Given this list of marker genes Plpp3, Synj1, Ephx2, Plppr2, Chrm5, Mtmr12, Mtmr1, Plpp5, Pip4p1, Plpp4, Fig4, Mtm1, Mtmr9, Inppl1, Sgpp1, Mtmr2, Plppr3, Synj2, Mtmr11, Inpp5d, Inpp5k, Mtmr6, Plpp6, Mtmr3, Pten, Inpp5b, Plppr4, Inpp4b, Plppr5 (NCBI Gene Id 75769), Inpp5a, Plpp2, Inpp5j, Plpp1, Inpp5f, Plppr1, Mtmr7, Inpp5e, Sacm1l, Sgpp2, Mtmr4, Pip4p2, Ocrl, Mtmr10, here is a description of the gene set: Mouse Gene Set: GOBP_PHOSPHOLIPID_DEPHOSPHORYLATION studied in species Mus musculus The process of removing one or more phosphate groups from a phosphorylated lipid, any member of a group of substances soluble in lipid solvents but only sparingly soluble in aqueous solvents.